The following is a description of a gene set: Reactome Pathway: Transcriptional regulation by RUNX1 The RUNX1 (AML1) transcription factor is a master regulator of hematopoiesis that is frequently translocated in acute myeloid leukemia (AML), resulting in formation of fusion proteins with altered transactivation profiles. In addition to RUNX1, its heterodimerization partner CBFB is also frequently mutated in AML.<br>The core domain of CBFB binds to the Runt domain of RUNX1, resulting in formation of the RUNX1:CBFB heterodimer. CBFB does not interact with DNA directly. The Runt domain of RUNX1 mediated both DNA binding and heterodimerization with CBFB, while RUNX1 regions that flank the Runt domain are involved in transactivation and negative regulation (autoinhibition). CBFB facilitates RUNX1 binding to DNA by stabilizing Runt domain regions that interact with the major and minor grooves of the DNA. The transactivation domain of RUNX1 is located C-terminally to the Runt domain and is followed by the negative regulatory domain. Autoinhibiton of RUNX1 is relieved by interaction with CBFB.<br>Transcriptional targets of the RUNX1:CBFB complex involve genes that regulate self-renewal of hematopoietic stem cells (HSCs), as well as commitment and differentiation of many hematopoietic progenitors, including myeloid and megakaryocytic progenitors, regulatory T lymphocytes and B lymphocytes.<br>RUNX1 binds to promoters of many genes involved in ribosomal biogenesis (Ribi) and is thought to stimulate their transcription. RUNX1 loss-of-function decreases ribosome biogenesis and translation in hematopoietic stem and progenitor cells (HSPCs). RUNX1 loss-of-function is therefore associated with a slow growth, but at the same time it results in reduced apoptosis and increases resistance of cells to genotoxic and endoplasmic reticulum stress, conferring an overall selective advantage to RUNX1 deficient HSPCs.<br>RUNX1 is implicated as a tumor suppressor in breast cancer. RUNX1 forms a complex with the activated estrogen receptor alpha (ESR1) and regulates expression of estrogen-responsive genes.<br>RUNX1 is overexpressed in epithelial ovarian carcinoma where it may contribute to cell proliferation, migration and invasion.<br>RUNX1 may cooperate with TP53 in transcriptional activation of TP53 target genes upon DNA damage.<br>RUNX1 is needed for the maintenance of skeletal musculature.<br>During mouse embryonic development, Runx1 is expressed in most nociceptive sensory neurons, which are involved in the perception of pain. In adult mice, Runx1 is expressed only in nociceptive sensory neurons that express the Ret receptor and is involved in regulation of expression of genes encoding ion channels (sodium-gated, ATP-gated and hydrogen ion-gated) and receptors (thermal receptors, opioid receptor MOR and the Mrgpr class of G protein coupled receptors). Mice lacking Runx1 show defective perception of thermal and neuropathic pain (Chen CL et al. 2006). Runx1 is thought to activate the neuronal differentiation of nociceptive dorsal root ganglion cells during embryonal development possibly through repression of Hes1 expression. In chick and mouse embryos, Runx1 expression is restricted to the dorso-medial domain of the dorsal root ganglion, to TrkA-positive cutaneous sensory neurons. Runx3 expression in chick and mouse embryos is restricted to ventro-lateral domain of the dorsal root ganglion, to TrkC-positive proprioceptive neurons (Chen AI et al. 2006, Kramer et al. 2006). RUNX1 mediated regulation of neuronally expressed genes will be annotated when mechanistic details become available. studied in species Homo sapiens part of: Generic Transcription Pathway, and this is the list of marker genes: SPI1, EP300, H2AZ2, H2BC9, H2AC18, H2BC26, SERPINB13, AUTS2, NR4A3, MIR378, PRKCB, PSMD6, RNF2, CSF2, NFATC2, HIPK2, PSMB7, MOV10, PSMC2, PSMD8, CCND2, H2BC3, PRKCQ, SIN3A, CBFB, SOCS3, H2AJ, PSMB5, PSMD1, LMO1, AGO1, H2AC20, CDK7, CSNK2A2, MIR18A, RING1, H2BC12, BMI1, PSMC5, H2AC7, SOCS4, ELF2, H2BC5, H3C1, TNRC6A, CBX6, SMARCB1, CR1, PSMA3 (proteasome 20S subunit alpha 3), AGO2, H2BC13, SMARCD3, ARID2, ELF1, TP73, YAP1, SMARCE1, PSMB1, PSMD12, GATA1, CBX8, GATA3, MIR675, GP1BA, CCND1 (cyclin D1), PSMA5, PSMD3, CREBBP, PSMC4, H2AB1, KCTD6, THBS1 (NCBI Gene Id 7057), SRC, ESR1 (estrogen receptor 1), PAX5, AGO3, MIR215, RBBP5, PSMD7, SMARCC2, H4C1, PSMB4, ACTL6A, MIR302B, KAT2B, H2BC14, PSMA2, PSMA1, TNRC6C (trinucleotide repeat containing adaptor 6C), IL3, CDK6, PCGF5, CSNK2B, H2AC14, PRMT6, KMT2B, CSNK2A1, FOXP3, H2BC17, SMARCC1, CBX2, TCF3, MYB, H2BC15, AGO4, PSMC3, IL2RA, ITCH, PHC1, RUNX2, MIR17, CLDN5, LIFR, PSMB2, IFNG, H2BC4, H2BC21, UBB, PHC3, SEM1, PTPN11, SMARCA4, PBRM1, RUNX1, CTSV, MIR106A, H2BC12L, ASH2L, MYL9, PHC2, TNRC6B, RYBP (RING1 and YY1 binding protein), CTLA4, PSMA7, PSMB6, H2BC1, YAF2, H2AX, SIN3B, RSPO3, LGALS3, HDAC1, PSMD13, ADRM1, SMARCA2, IL2, CTSL, MNAT1, TCF12, TJP1, H3-3A, KMT2D, ARID1B, H19 (H19, imprinted maternally expressed transcript), UBA52, CCNH, LMO2, TAL1, TNFRSF18, SETD1A, AXIN1, CCND3, MIR20A, PSMA4, RPS27A, ZFPM1, PSMA6, ARID1A, UBC, NFE2 (NCBI Gene Id 4778), SETD1B, WDR5, PF4, SMARCD1, GPAM, OCLN, PSMC6, BLK, H3C15, PSMD2, PRMT1, ITGA2B, DPY30, ACTL6B, MIR27A, LDB1, PSMD11, KMT2C, PML, KMT2A, GATA2, PSMD14, H2AC6, H2AC4, H2BC11, PSMC1, SMARCD2, ABL1, PSMB3, SCMH1, CBX4, CTSK